Given this list of marker genes HMGCS1, NR3C1, MARCHF6, TCERG1, RAB10, PCDH9, PEG3, UGT1A1, TSEN2, TRAM1, STXBP5, CEP120, UBE3A, VRK2, TMED9, MLANA, DOCK4, HS6ST3, NR2C2 (nuclear receptor subfamily 2 group C member 2), UGT1A4, RBM24, FAT3, YWHAG, NCOA2, LTBP1, PIGA, CYP26B1, ZBTB34, GIGYF1, SLC23A2, RAP2C, PDGFRA, DCP2, SOBP, IPO5, ANGPTL1, ZNF705EP (NCBI Gene Id 790968), JAG1, EPHA2, FNBP1L, PLAG1, FBXL2, NPAS3, ACADSB, PHC3, ERG, MCIDAS, NTNG1, EPN1, ATL1, MINDY3, RNF145, MBNL3, IGDCC4, RANBP6, ARHGEF18, PPM1E, SIK1, TNFAIP3, OLFM1, FAM24A, HYCC2, MYBL1, WNK1, TFAP2C, C6orf120, IKZF5, NBPF15, MAP3K20, TIAM1, FNIP2, PRKACB, CDC25B, GLCCI1, PLCL1, SDC2, CREBRF, KLHDC10, HIC2, BICD2, KIF3A, DSTYK, RAB8B, KIAA0408, TMEM41B, SAMTOR (NCBI Gene Id 154743), HS6ST2, RCOR3, IBA57, MAP3K2, DEK, CXCL12, TCF4, FOXJ3, B3GNT5, IRS2, SLC16A7, PAQR9, SPAG9 (NCBI Gene Id 9043), PGRMC2, AQP11, TTLL7, ASTN1, ELAVL2, HOXC13, C11orf54, STXBP1, P2RY1, C6orf141 (chromosome 6 open reading frame 141), HCAR2, WDFY3 (NCBI Gene Id 23001), HSDL1, SCD5, SLC20A1, SUPT6H, TSHZ3, ANP32E, TCF24, KIDINS220, HGF, PRR11, JAGN1, ELK3, TNRC6B, KLF6, AP3S1, APBB2, ZCCHC3, DR1 (down-regulator of transcription 1), PIAS2, YAP1, DNAJC13, SCN2B, IFNAR1, PPM1L, HNRNPF, NRXN1, HCN1, LPP, ATP8A2 (ATPase phospholipid transporting 8A2), DMWD, SLC14A1, PIKFYVE, CALCR, PLEK, SPRYD3, GJC1, PITX2, UGT1A6, OSBPL11, SOCS5, KCTD20, SPOPL, VCAN, CHD2, C1orf21, MYH10, RASSF8, NBPF11, CRLF3, RSPO2, UGT1A9, KMT2A, CERS6, RIMS1, LPAR3, TRHDE, RAPGEF5, C14orf28, CORIN, SCHIP1, MPHOSPH9, ELMOD1, ATXN1, CCDC80, USP49, CTNND2, TPK1, GSG1, IL6R, TRUB1, GNA13, ABL2, STON2, SLC30A4 (solute carrier family 30 member 4), TNS3, NUFIP2 (NCBI Gene Id 57532), HEATR5A, REEP3, ERC2 (NCBI Gene Id 26059), TMPRSS11F, C5orf24, BRMS1L, EGFR, XPR1, KLF12, NBPF20, GCNT2, CDC14A, PTPRG, ARL4A, ABHD18, ZNF644, MNX1, KAZN, TP53INP1, NME1, BNC2 (NCBI Gene Id 54796), KHDRBS3, FOXA2 (NCBI Gene Id 3170), PAFAH1B2, EDEM1, LYPLA1, GRB2, NAP1L2, TSC1, RBM20, SFPQ, RAB38, ZNF284 (zinc finger protein 284), NBPF14, RNFT1, PRELID2, DLC1, CNTN1, FHIP2A (FHF complex subunit HOOK interacting protein 2A), SMC5, GPR6, E2F3 (E2F transcription factor 3), GAB1, TADA1, SESTD1, KAT6B, HS2ST1, ZYG11B, CCND2, MSANTD4, TMTC1, GPC2, ATXN7, QSER1, C5orf63, FAM91A1, ACO1, MAP3K19 (mitogen-activated protein kinase kinase kinase 19), XKR9, PLAGL2, PDCD4, JAZF1, TNS1, NDFIP2, LMBR1, ZNF416, LYSMD3, ZEB1, GABPB1, MYT1L, MACC1, NFASC, ARRB1, GSN, ITGA6, TCF12, CDKN3, EPHA7, MIER1, NRIP3 (NCBI Gene Id 56675), HIPK3, FAM168B, KCTD3, RHEB, CHP1, CDC42EP3, GLS, RALGPS2, SLC1A7, ACOT7, C21orf91, FMR1, ANKRD44, CDC25A, CLASP2, TOMM7, NEK6, CDK8, SLC19A2, BBS10, EVI5L, TGFB2, PAPPA, RSAD2, CCDC85C, MBNL1, NBPF9, SLAIN2, PURA, UNC5C, TMEM135, C2orf69, RB1CC1, HCAR3, MYRIP, NCKAP5, NBPF8, ARPC5, PFKM, PHLPP2, SEMA6A, MAPK10, EXOC5, ITPRIPL2, PHYHIPL, WWTR1, NUCKS1, GPAT4, RARB, CD2AP, H2AZ1, CFAP20DC, PIN4, FAM210A, SLC35D1, PRRG1, ENSG00000275993, SMIM15, TAF12, SUGT1, PDK2, ZCCHC24, OPA3, AK2, HDAC4, RBM33, ARFGEF3, YTHDF2, ALS2, DUSP3, PTCH1, MED6, CSTA, MPZL2, MDM1, PPARA, TMEM130, ALKAL2, CCDC6, BRD3, BEAN1, PPT2, ATP8A1, SCUBE2, DAPK1 (NCBI Gene Id 1612), LGR4, TTBK2 (tau tubulin kinase 2), HMG20A, CEP43, LSAMP, PLXNA4, KIF17, ST3GAL3, CDK13, MIER3, LHX6, NIPAL3, RBM12, PCDH10, SRC, URGCP, ZEB2, PRKCE, MN1, IQCJ-SCHIP1, SMIM7, LOXL3, MAP2K4, TMEM170B, UGT1A3, MFF, EGR2, RSL24D1, CBL, DCUN1D3, CRMP1, INO80D, RBM46, STX2, FKBP1A, IFFO2, CREB1, ZFR, WDR33, MAP7D1, FKBP5, LHFPL6, IKZF2, here is a description of the gene set: studied in species Homo sapiens Genes predicted to be targets of miRBase v22 microRNA hsa-miR-200a-3p in miRDB v6.0 with MirTarget v4 prediction scores > 80 (high confidence targets). Human Gene Set: MIR200A_3P from publication Chen Y, Wang X (PMID 31504780)